Given this list of marker genes GNG11, GNG13, GNGT1, GNB5, GNG12, GNAS, GNG8, GNB1, GNGT2, GNG2, PTGIR, GNG10, GNB2, GNG3, GNG5, GNG7, GNB4, GNG4, GNB3, here is a description of the gene set: species: Homo sapiens part of: Platelet homeostasis Prostacyclin (PGI2) is continuously produced by healthy vascular endothelial cells. It inhibits platelet activation through interaction with the Gs-coupled receptor PTGIR, leading to increased cAMP, a consequent increase in cAMP-dependent protein kinase activity which prevents increases of cytoplasmic necessary for activation. PGI2 is also an effective vasodilator. These effects oppose the effects of thromboxane (TXA2), another eicosanoid, creating a balance of blood circulation and platelet activation. Reactome Pathway: Prostacyclin signalling through prostacyclin receptor